Given this list of marker genes Slc9a5, Slc17a6, Slc9a9, Slc17a7, Slc24a2, Slc9a3, Slc9a8, Slc9a6, Slc24a4, Slc9a2, Slc24a1, Tmco3, Slc9a4, Slc24a3, Slc9a7, Slc9a1, Slc9c1, Slc24a5, here is a description of the gene set: Catalysis of the active transport of a potassium ion across a membrane by a mechanism whereby two or more species are transported in opposite directions in a tightly coupled process not directly linked to a form of energy other than chemiosmotic energy. studied in species Mus musculus Mouse Gene Set: GOMF_SOLUTE_POTASSIUM_ANTIPORTER_ACTIVITY